Given this list of marker genes Tsnax, Dicer1, Henmt1, Tarbp2, Tsn, Tert, Prkra, Ago2, here is a description of the gene set: A process leading to the generation of a functional small interfering RNA (siRNA). Includes the cleavage of double-stranded RNA to form small interfering RNA molecules (siRNAs) of 21-23 nucleotides. May also include amplification of the siRNA by RNA-directed RNA polymerase. species: Mus musculus Mouse Gene Set: GOBP_SIRNA_PROCESSING